The following is a description of a gene set: Reactome Pathway: Adenosine P1 receptors part of: Nucleotide-like (purinergic) receptors The adenosine receptors (P1 receptors) are a class of purinergic receptors, G-protein coupled receptors with adenosine as their endogenous ligand.In humans, there are four adenosine receptors. Each is encoded by a separate gene and the four receptors have distinct, though overlapping, functions. For instance, both A1 and A2A receptors play roles in the heart, regulating myocardial oxygen consumption and coronary blood flow. They also have important roles in the brain, regulating the release of other neurotransmitters such as dopamine and glutamate. The A2B and A3 receptors are located peripherally and are involved in processes such as inflammation and immune responses. Fredholm BB et al, 2001). studied in species Homo sapiens, and this is the list of marker genes: ADORA2B, ADORA1, ADORA3, ADORA2A